The following is a description of a gene set: Mouse Gene Set: GOBP_COMPLEMENT_ACTIVATION studied in species Mus musculus Any process involved in the activation of any of the steps of the complement cascade, which allows for the direct killing of microbes, the disposal of immune complexes, and the regulation of other immune processes; the initial steps of complement activation involve one of three pathways, the classical pathway, the alternative pathway, and the lectin pathway, all of which lead to the terminal complement pathway., and this is the list of marker genes: Masp1, Colec10, Cr1l (NCBI Gene Id 12946), Ighg2c, Phb1, Cfh, Cd55b, Vsig4, C4a, Il1b, C1s1, Cd59b, C1qc, Ighg1, Mbl1, C1ra, Cfp, Crp, Cd59a, C9, Cfhr1, C7, Serping1, Hc, C1s2, Cfhr2, C2, Cfd, Ighm, C8g, C1rl (complement component 1, r subcomponent-like), Igha, Colec11, A2m, C8a, Cd46, Cr2, C1qbp, Cfb (NCBI Gene Id 14962), Trem2, Fcna, C8b, Zp3r, Ighe, Cfi, C4bp, Mbl2, C1rb, Ighg3, Cd5l, C1qb, Susd4, C4b, C6, Masp2, Ighg2b, C1qa, Rgcc, Krt1, Cfhr4, Fcnb, C3, Cd55